The following is a description of a gene set: from publication Yu D, Cozma D, Park A, Thomas-Tikhonenko A (PMID 16382050) Genes down-regulated in B cell lymphoma tumors expressing an activated form of MYC. species: Mus musculus Human Gene Set: YU_MYC_TARGETS_DN The involvement of the c-Myc transcription factor in neoplastic transformation is well documented. However, which of its numerous target genes are crucial for tumorigenesis remains a frequently contested issue. We have recently established a non-transgenic murine model for B-cell lymphoma based on neoplastic conversion of p53-null bone marrow cells by conditionally active Myc. Using this model, we have identified a number of genes whose expression levels are affected by Myc during B-lymphomagenesis. Here we discuss their possible roles in neoplastic processes and describe an experimental approach allowing in vivo validation of these roles. We demonstrate that lymphoma cells overexpressing one of the Myc targets, the interleukin-10 receptor gene, have a very strong selective advantage over low IL10R expressors. Furthermore, Mcl1, a presumptive IL10R effector, also confers selective advantages when overexpressed in Myc-transformed hematopoietic cells. Thus, both IL10R and Mcl1 might be amenable to therapeutic interventions, and new targets can be identified and validated using the selection approach., and this is the list of marker genes: HLA-DQA2, GUCD1 (guanylyl cyclase domain containing 1), ARHGAP45, WFDC21P, BLK, HLA-B, IGLV4-69 (NCBI Gene Id 28784), CMAHP, MYO7A, OLFM1, HLA-DMB, DGKA, LTB, PYGM, ABCA1, IFI16, PLD4, TXNDC16, GDI1, PRKCB, PTPRC, ARHGEF1, UNC93B1, HLA-DOB, RAG1, CTSH, RGL2, EVL, SRPK3, MACF1, CD37, CD2, MAP4K2, KLF2, IL4I1, HLA-DMA, MS4A1, SIPA1, KLF3, SLFN12, IGHD, CD74, SSPN, GPR148, HLA-DQB1, ACP5, CD1D, GGA2, RBMS1, GAD1, ZCCHC7, ARID3B, GNS, LIFR, ERO1B (NCBI Gene Id 56605, endoplasmic reticulum oxidoreductase 1 beta), IL10RA, IGKV4-1, BTG1, MGST1, HLA-DRB1, SPIB